The following is a description of a gene set: This event has been computationally inferred from an event that has been demonstrated in another species.<p>The inference is based on the homology mapping from PANTHER. Briefly, reactions for which all involved PhysicalEntities (in input, output and catalyst) have a mapped orthologue/paralogue (for complexes at least 75% of components must have a mapping) are inferred to the other species. electronically inferred by orthology from the curated human pathway species: Mus musculus part of: Cellular responses to stress Reactome Pathway: Cellular response to mitochondrial stress, and this is the list of marker genes: Eif2s3x, Yme1l1, Phb2, Stoml2, Oma1, Eif2ak1